Given this list of marker genes NME9, NME3, CAD, NME5, AK3, NME2P1, NME2, NME1, NME6, ENTPD7, NME7, NME4, here is a description of the gene set: The chemical reactions and pathways involving UTP, uridine (5'-)triphosphate. Human Gene Set: GOBP_UTP_METABOLIC_PROCESS studied in species Homo sapiens